The following is a description of a gene set: species: Mus musculus Mouse Gene Set: GOBP_INSULIN_METABOLIC_PROCESS The chemical reactions and pathways involving insulin., and this is the list of marker genes: Ceacam2, Pax6, Pcsk1, P4hb, Ier3ip1, Pcsk2, Nlgn2, Ide, Ceacam1, Ern1, Yipf5, Nucb2, Ins2, Tcf7l2, Blvra, Hid1, Ero1b, Hsp90b1, Ctsd (NCBI Gene Id 13033), Fosl2, Jagn1, Cela2a, Slc30a8, Cpe, Slc30a5